The following is a description of a gene set: Human Gene Set: HP_BREATHING_DYSREGULATION species: Homo sapiens Breathing dysregulation, and this is the list of marker genes: INPP5E, TLL1, TMEM67, AHI1, PHOX2B, ASCL1, ACTC1, KYNU (kynureninase), CITED2, TBX20, MYH6, RET, NDUFS6, TMEM216, ELP1 (NCBI Gene Id 8518), GATA4, GATA6, RPGRIP1L, CEP290, NKX2-5